The following is a description of a gene set: Reactome Pathway: Developmental Lineage of Mammary Gland Luminal Epithelial Cells Most postnatal mammary gland development originates from unipotent lineage-committed progenitors (luminal progenitor cells and myoepithelial progenitor cells), which are located in the basal epithelium. Based on the experiments conducted on human mammary organoids, FGF2 and FGF7 are not necessary for the differentiation of luminal epithelial cells, but they are needed for the establishment of proper architecture of mammary ducts. Luminal progenitors can commit to either the ductal fate, producing luminal epithelial cells that line the mammary ducts, or to the alveolar fate, producing milk-secreting alveolar cells, with NOTCH and hormone receptor signaling playing critical roles in fate determination, so that hormone receptor positive luminal progenitor cells commit to the luminal epithelial lineage, while hormone receptor negative luminal progenitor cells commit to the alveolar lineage. Single cell omics studies have identified diverse subtypes of luminal progenitor cells, of which hormone receptor positive and negative have been characterized the best although not extensively. In human and mouse mammary glands, a putative common ancestral luminal progenitor that would give rise to hormone receptor negative and positive luminal progenitors has not been identified, and it is thought that subpopulations of mammary stem cells (MaSCs) commit to either of the two luminal lineages, but an uncommitted luminal progenitor has been described in the cow mammary gland. Both mouse and human luminal progenitor cells display plasticity and can be reprogrammed to a stem-like state by changes in the microenvironment. Lineage tracing experiments in mouse suggest that luminal progenitors are the key drivers of mammary gland morphogenesis during puberty and alveologenesis. Expression of luminal, myoepithelial and stem cell markers in human luminal cells appears to be less clear-cut than what has been reported in corresponding mouse mammary cell populations, but the hierarchical organization of the luminal cell compartment is similar to the one described in mouse and consists of nonclonogenic luminal cells, and relatively differentiated (EpCAM+CD49f+ALDH-) hormone receptor positive and undifferentiated (EpCAM+CD49f+ALDH+) hormone receptor negative luminal progenitors that express some genes associated with alveolar differentiation. Approximately one-quarter of human breast samples may contain an additional luminal progenitor population, characterized by low expression of ERBB3 and low proliferative potential, but this rare population has not been reported in other studies of the human mammary gland. Due to their plasticity, the prevalence of human luminal cell markers determined in situ may differ from the prevalence observed when luminal cells are propagated in vitro or in vivo. Finally, profiles of human luminal progenitor and mature cells likely differ between different breast lobule types. A human breast is composed of 11-48 central ducts that radiate outward from the nipple and end in terminal ductal lobular units (TDLUs). Each lobe is composed of heterogeneous lobules at different developmental stages, where Type I lobules are the least developed and Type IV are the most developed and present only during pregnancy and lactation. part of: Developmental Lineages of the Mammary Gland species: Homo sapiens, and this is the list of marker genes: EGF, AREG, TGFA